The following is a description of a gene set: Genes in the cancer module 400. studied in species Homo sapiens Human Gene Set: MODULE_400, and this is the list of marker genes: MTTP, MGP, AMELY, EXTL1, JAK3, IL6ST, TIE1, GNG11, COL5A1, LMOD1, AHSG, EFEMP1, SRD5A2, STC1, ABCA8, SLIT2, TCF15, IBSP, KIF25